The following is a description of a gene set: species: Mus musculus Mouse Gene Set: chr5G3, and this is the list of marker genes: Gpr12, Pomp, Katnal1, Pan3, Gm15997, 4930449I24Rik, Gm29793, Slc7a1, Pdx1, 1700001J03Rik, Gm24105, Vmn2r18, D730045B01Rik, Gm8615, Usp12, N4bp2l1, Gm26013, 4933425D22Rik, 1700028E10Rik, Mir7k, Fry, Cyp3a59 (NCBI Gene Id 100044462), Gm29778, Gtf3a, Gm3415, Gm25091, Gm15407, 1700013A02Rik, Gm8458, Kl, Polr1d, Gm8675, Gm34248, Stard13, Gm24630, 4930573C15Rik, Alox5ap, 2210417A02Rik, Mtus2, Slc46a3, Rpl21, Rnf6, Gm15410, Gm3402, Gm42529, Mtif3, Zar1l, N4bp2l2, Gm8494, Rxfp2, Gm6370, Vmn2r-ps26, Gm6054, Gm18753, Nme-ps1, 1810059H22Rik, Cdk8, Rfc3, Gm36447, Gm6408, Gm3409, Hmgb1, Gm19719, Plut (NCBI Gene Id 70147), Gm36378, Gm23202, Brca2, Uspl1, Gm21048, 8430423G03Rik, Cdx2, Gm23641, Gm15408, 5930430L01Rik, Gm5565, Wdr95, Flt3, Gsx1, Tex26, 1700041I07Rik, B230303O12Rik, Gm3404, Mm2pr, Gm2566, Lnx2, Gm15411, Wasf3, Ubl3, Rasl11a, Medag, Gm29815, Gm26597, 4930505K14Rik, Hsph1, Gm24556 (NCBI Gene Id 115486306), Vmn2r-ps28, D5Ertd605e (NCBI Gene Id 52388), Gm20005, Gm6309, Pds5b, Gm21221, Gm7041, Gm5, Vmn2r-ps25, Gm19617, Gm35648, Urad, 5430435K18Rik, Flt1 (FMS-like tyrosine kinase 1), 4930500F04Rik (NCBI Gene Id 74932), Gm34333, BC028471, Gm10167, Rps10-ps4, Gm42788, Gm36241, B3glct, Gm36186